The following is a description of a gene set: Regorafenib is a type II TKI that is approved for the treatment of advanced gastrointestinal stromal tumors. Although regorafenib is effective against a number of KIT and PDGFR mutations, it only weakly inhibits the activity of the most prevalent PDGFRA allele, D842V. Reactome Pathway: Regorafenib-resistant PDGFR mutants studied in species Homo sapiens part of: Drug resistance of PDGFR mutants, and this is the list of marker genes: PDGFRA